The following is a description of a gene set: from publication Travaglini KJ, Nabhan AN, Penland L, Sinha R, Gillich A, Sit RV, Chang S, Conley SD, Mori Y, Seita J, Berry GJ, Shrager JB, Metzger RJ, Kuo CS, Neff N, Weissman IL, Quake SR, Krasnow MA (PMID 33208946) studied in species Homo sapiens Human Gene Set: TRAVAGLINI_LUNG_CD4_MEMORY_EFFECTOR_T_CELL, and this is the list of marker genes: CD3D, PBXIP1, LDHB, RPS29, ITGB1, GSTK1, HSPA8, EVL, ITK, RPS27, PCED1B-AS1, CCR6, CRIP2, CTLA4, CD5, BCL11B, RPS3, TMEM123, SYNE2, CD6, SARAF (store-operated calcium entry associated regulatory factor), ICAM3, RORA, SUSD3, ETS1, HLA-A, CAPN2, CD96, RASGRP1, RPL23A, TRADD, RCAN3, RPL13A, LEF1, GIMAP7, CD3E (CD3 epsilon subunit of T-cell receptor complex), SKAP1, LINC00892, IFITM1, SPOCK2, IL10RA, IL7R, SLC38A1, SLFN5, CD52, GPR183, CD28, CORO1A, IL32, ARHGAP15, TTC39C, PRDM1, CLEC2D, TRAF3IP3, CD2, INPP4B, LCK, TRAT1, TNFRSF25, IL2RG (interleukin 2 receptor subunit gamma), MIAT, HNRNPLL, TXNIP, CD40LG, ICOS, CNN2, HINT1, SIT1, CDC14A, SLAMF1, SEPTIN1